The following is a description of a gene set: studied in species Homo sapiens Human Gene Set: GOBP_PROLACTIN_SECRETION The regulated release of prolactin, a peptide hormone that stimulates lactation, from secretory granules in the anterior pituitary., and this is the list of marker genes: VIP, TACR2, UBE2Q1, NMU, ABAT